The following is a description of a gene set: studied in species Homo sapiens Genes having at least one occurrence of the motif TGCTGAGTCAY in the regions spanning 4 kb centered on their transcription starting sites. This matches the NFE2 transcription factor binding site V$NFE2_01 (v7.4 TRANSFAC). Human Gene Set: NFE2_01, and this is the list of marker genes: BCL7A, HDAC3, ANGPTL4, TUBA4B, FHIT, PCDH9, JAZF1, GNRHR2, PKN3, RHOG, AKT3 (AKT serine/threonine kinase 3), SGMS1, LMOD1, OMG, NLK, ABCD1, CAPN12, METAP1D, NUDT10, SLC38A3, RIT1, MDFI, ANGPT1, PVALB, ZNF217, GADD45G, BNIP3, PSMD12, ABHD4, ATXN7L2, NRIP3, ELMO3, ZNF830, SERPINB5, YWHAG, CHRNA2, NRN1L, PRDM1, TUBA4A, MAP1A, ENO1, SPATS2, MAP4, ESRRG, SQSTM1 (NCBI Gene Id 94002), DIAPH1, PLBD2, CMAS, PSMD7, KCNA2, GSTP1, DPH1, TMCC1, HSPB8, RABGAP1L, PAK5, ALS2CL, SLC22A18AS, PLEC, SPTA1, SLC7A8, DRP2, DUSP13B, NLGN3, WDR81 (NCBI Gene Id 780925), LYVE1, TRAF3, LINC02908, ALDOA, SNX10, TNRC6A (trinucleotide repeat containing adaptor 6A), USP13, STMN2, GTF2B, PPP2CA, FGF9, VAPA, TEAD1, NDRG3, SCUBE3, PTPRR, TNXB, ROM1, SNCB (NCBI Gene Id 6620), SLC31A1, ST3GAL2 (NCBI Gene Id 729518), IL10, SCRN1, LINC00649, PCP4, MYB, ABCF3, COBL, PAK6, LINC02694, RIN1, MEPCE, REXO2, LRRFIP2, TTC28, SEL1L3, EML3, BLMH, WDFY3, TOB1, SPRED1, COL15A1, H1-0, SLC26A1, CLCN5, TEX19, YIF1A, ADRA1A, HOXA11, SHC3, ZC2HC1C, EPHA2, CNTD1, FAM184A, NDP, SLC11A1, COL5A3, ABCB6, P2RX6, VASP (vasodilator stimulated phosphoprotein), TENM3-AS1, HCLS1, COA3, GAST, VAT1, IPO11, BTK, ARHGAP8, MDM2, AMBN, NUDCD1, TBXAS1, ITM2B, TUBA1C, SHISA6, HS6ST2, TMEM151A, MACO1, BAZ2A, NCDN, ANKRD22, RCAN2, RBBP7, MMP19, LINC03124, C11orf87, PSMD11, ICAM2, MAST2, SLC16A6, PSMA3, CST7, FHL3, PHLDA2 (pleckstrin homology like domain family A member 2), MITF, S100A2, ABCA2, ASS1, N4BP1, TBL1X, LRP1B, RBPMS, HSPA9, ZCWPW1, GADD45A, CPNE8, DTNA, PLEKHH3, IL6, TTLL7, CLSTN3, ID2, TINAG, RB1CC1, NUDT11 (nudix hydrolase 11), GLRX5, RELL2, MAPK12, TBC1D10B, GAB2 (NCBI Gene Id 9846), FBXO2, CDKN1A, PADI4, PRR7, NOTCH4, SCEL, CLIC1, PEX11B, ZBTB37, HS3ST2, TBC1D17, IRAK1 (interleukin 1 receptor associated kinase 1), GAA, PSMA1, VEGFD (vascular endothelial growth factor D), ZFAND5, CHN2, EYA3, MNT, PDE1B, WDFY3-AS2, DYNC1H1, BAG2, ZNF771, CAPN6, POLD4, PIANP, SYNGR1, LRRC2, ANXA7, FGF12, SLC25A51 (solute carrier family 25 member 51), EIF4G1, SV2B, FBXW11, SRC, DDX17, TIAL1, GGN, MIR22HG (NCBI Gene Id 84981), CALB2, ATL1, LCTL, CLC, LAMC1, MMRN2, SLC22A18, SYN1, GABARAPL1, FGF11, SMPX, PHF23, CDK9, TINAGL1 (tubulointerstitial nephritis antigen like 1), NRDC, HS3ST3B1, IDS (iduronate 2-sulfatase), CLASP1, MAP2, TBL1Y, PTPRN, KBTBD8, SEPTIN9, SNCG, CPA6, PPP2R2C, TLL1, DTX2 (deltex E3 ubiquitin ligase 2), CYTOR, PSMD2, SYT2, DCTN2, MAPK10 (mitogen-activated protein kinase 10), CA7, AKT1S1, SPEG, GAPDH, LONRF3, VEZF1, C1QTNF8, FBXO44, RTN4RL2, BACH1, MAFF, EEF1A2, CCT6B, NECAB3, DOC2A, GCAT, BCL3